Given this list of marker genes Tgfbr3l, Acvrl1, Tgfbr2, Acvr2a, Amhr2, Bmpr2, Acvr1c, Acvr2b, Bmpr1a, Acvr1b, Tgfbr1, Acvr1 (activin A receptor, type 1), Tgfbr3, Bmpr1b, here is a description of the gene set: Mouse Gene Set: GOMF_TRANSFORMING_GROWTH_FACTOR_BETA_RECEPTOR_ACTIVITY studied in species Mus musculus Combining with a transforming growth factor beta (TGFbeta) and transmitting the signal from one side of the membrane to the other to initiate a change in cell activity by catalysis of the reaction: ATP protein serine = ADP + protein serine phosphate, and ATP + protein threonine = ADP + protein threonine phosphate.